The following is a description of a gene set: Any process that modulates the frequency, rate or extent of cardiac muscle contraction via the regulation of the release of sequestered calcium ion by sarcoplasmic reticulum into cytosol. The sarcoplasmic reticulum is the endoplasmic reticulum of striated muscle, specialised for the sequestration of calcium ions that are released upon receipt of a signal relayed by the T tubules from the neuromuscular junction. species: Mus musculus Mouse Gene Set: GOBP_REGULATION_OF_CARDIAC_MUSCLE_CONTRACTION_BY_REGULATION_OF_THE_RELEASE_OF_SEQUESTERED_CALCIUM_ION, and this is the list of marker genes: Ank2 (ankyrin 2, brain), Tmem38b, Tmem38a, Slc8a1 (NCBI Gene Id 319418), Casq2, Dmd, Pln, Cacna1c, Ryr2, Fkbp1b